The following is a description of a gene set: Mouse Gene Set: GOBP_REGULATION_OF_NEURON_DIFFERENTIATION Any process that modulates the frequency, rate or extent of neuron differentiation. studied in species Mus musculus, and this is the list of marker genes: Eif4enif1, Neurog1, Vwc2l, Lmx1a, Six3os1, Tcf3, Phox2b, Hoxa2, Duoxa1, Bend6, Sfrp1, Rgs6, Notch1, Foxo3, Fmr1, Ednrb, Neurod1, Trim32, Numb, Socs2, Mef2c, Nepro, Rhoa, Ptbp1, Ngf, Id4, Nap1l2, Eya1, Trpc5, Ptger3, Shoc2, Efna3, Pou4f2, Nf1, S1pr5, Grip2, Gli3, Cav1, Med1, Bin1, Tle6, Cntn4, Mir9-3, Lsm1, Bcl2, Tgif1, Dll1, Wdr62, Gpr37l1, Nlgn1, Zfp536, Nr2e1, Six1, Hey1, Hey2, Isl2, Sall1, Cdk5rap2, Nkx6-1, Gdf6, Nkx2-2, Dab1, Upf3b, Cd24a, Kdm4a, Impact, Nrep, Bmp7, Zhx2, Tfap2a, Ywhag, Dicer1, Fezf2, Ccr5, Bmp6, Id2, Mmd2, Tbx6, Sox21, Alk, Cxcl12 (C-X-C motif chemokine ligand 12), Il6, Fgfr3, Pcp4, Lrrk2, Tiam1, Ctdsp1, Fgfr1, Adra2b, App, Ncoa1, Mir124a-2, Trpc6, Pax6, Shh, Pbx1, Aspm, Gsk3b, Opa1, Mir124a-1, Wnt3a, Isl1, Rtn4, Casz1, Ttc3, Arhgef2, Hoxd3, Mycn, Notch3, Cdon, Mmd, Map3k13, Tgif2, Brinp3, Gdf5, Ferd3l, Hmg20a (high mobility group 20A), Lbx1, Tcf12, Spag9, Bnip2 (BCL2/adenovirus E1B interacting protein 2), Esrp1, Nbl1, Fgf2, Neurog2, Dtx1, Reln, Vwc2, Ifng, Eif4g1, Bmp4, Dpysl2, Ltk, Disp3, Sin3a, Atoh1, Calr, Irx3, Fgf20, Zeb1, Rest, Fuom, Brinp1, Mettl14, Zc4h2, Mir212, Gata2 (GATA binding protein 2), Sox2, Zfhx2, Gdpd5, Tcf4, Six3, Bcl11a, Tunar, Mib1, Neurod2, Ascl1, Cntn2, S100b, Mtor, Nkx2-5, Bex1, Nbn, Meis1, Nkx6-3, Etv5, Ccl5, Mir133b, Heyl, Bcl6, Hes5, Rara, Dixdc1, Hmg20b, Epo, Foxg1 (forkhead box G1), Olig2, Prox1, Mapk8, Ect2, Dmd, Mosmo, Mir132, Apbb1, Dlx1, Sox3, Sox8, Map1b, Eif2ak4, Rac3, Gdf11, Gli2, Mag, Cntf, Rap1gap, Gdf7, Rock1, Zfhx3, Rnf112, Sox5, Ret, Hes1, Timp2, Slc6a4 (NCBI Gene Id 216958), Mir9-2, Trp73, Cyb5d2, Foxa2, Fezf1, Bcl11b, Lin28a, Sfrp2, Actr3, Eif4e, B2m, Dlx2, Kctd11, Il1b, Kdm4c, Adra2c, Mycl, Dleu2, Pten, Cit, Itgb1, Nox1 (NADPH oxidase 1), Foxa1, Dkk1, Neurog3, Sh3gl3, Dnmt3b, Tlx3, Bmp2, Jag1, Bdnf, Mir9-1, Ngfr, Sox11, Mapk8ip3, Hes3, Brinp2, Cpne1, Ddx6, Rac1, Mir124a-3, Atn1, Gprc5b, Sox9